Given this list of marker genes Kpna1, Mtss1, Pdap1, Gcdh, Cbln2, Lrp8, Tfam, Haspin, Vdac2, Ifrd1, Ids, Crebzf, Rsbn1, Trip4, Kcnh8, Nadk2, Fgf9, Gng12, Zdhhc9, Rab5c, Tshz3, Ugcg, Adam10, Palld, Esp3, Hmbs, Cpsf6, Il18rap, Kctd10, Cideb, Mrpl41 (mitochondrial ribosomal protein L41), Usp7, Gls, here is a description of the gene set: from publication Chen Y, Wang X (PMID 31504780) Mouse Gene Set: MIR_409_5P Genes predicted to be targets of miRBase v22 microRNA mmu_miR_409_5p in miRDB v6.0 with MirTarget v4 prediction scores > 80 (high confidence targets). studied in species Mus musculus